The following is a description of a gene set: Human Gene Set: QIU_PBMC_HEPTATITIS_B_SURFACE_ANTIGEN_AGE_UNDER50_NON_RESPONDERS_VS_RESPONDERS_3DY_UP Genes up-regulated in peripheral blood mononuclear cell non-responders vs responders in adults (<50) after exposure to Heptatitis B surface antigen vaccine (HBsAg), time point 3D from publication Qiu S, He P, Fang X, Tong H, Lv J, Liu J, Zhang L, Zhai X, Wang L, Hu Z, Yu Y (PMID 29580160) studied in species Homo sapiens Individuals fail to elicit protective antibody after hepatitis B vaccination remain at risk for hepatitis B virus infection. Analysis of the transcriptome of peripheral blood mononuclear cells (PBMCs) is essential to elucidate the characteristics of gene expression in non-responders. In this study, we enrolled seven responders who had received three injections and seven non-responders who had six injections of hepatitis B vaccine before. All the participants were then vaccinated with a three-dose boost regimen. Microarray analysis and Luminex assay were applied to examine mRNA expression and Th1/Th2/Th9/Th17/Th22/Treg cytokine and chemokine profiles in non-responders and responders. Differentially expressed genes in PBMCs of non-responders at 5 time points, i.e. pre-vaccination, 3<sup>rd</sup>, 7<sup>th</sup>, 28<sup>th</sup> day post the first dose vaccination and 7<sup>th</sup> day post the second dose vaccination indicated a dense network trend. Compared with responders, nine coding genes (BPI, DEFA1B, DEFA4, CEACAM8, MMP8, FOLR3, LTF, TCN1 and TKTL1) were significantly up-regulated in non-responders at all 5 time points, which could probably be the characteristic genes in hepatitis B vaccine non-responsiveness. Gene ontology analysis revealed that most of the DEGs were related with immune responses. Validation results of these genes using quantitative real-time polymerase chain reaction were mostly consistent with the results of microarray. Cytokine analysis demonstrated that IL-27 and CXCL12 concentrations in responders were significantly higher than non-responders on the 3<sup>rd</sup> day after the first dose and 7<sup>th</sup> day after the second dose of vaccination, respectively. No significant difference was observed in other cytokine and chemokine signatures between the two groups. In conclusion, our results revealed characteristic transcriptome and cytokine changes in hepatitis B vaccine non-responders after boost immunization., and this is the list of marker genes: ANXA3, FOLR3, ARG1, TKTL1, BPI, TCN1, DEFA4, ABCA13, CEACAM1, MMP8, CEACAM8, IFNG, DEFA1B (NCBI Gene Id 728358), MS4A3, LTF